The following is a description of a gene set: species: Mus musculus Mouse Gene Set: GOBP_DEFINITIVE_ERYTHROCYTE_DIFFERENTIATION Erythrocyte differentiation which occurs as part of the process of definitive hemopoiesis., and this is the list of marker genes: Smarca4, Rbfox2, Zfpm1, Gata1, Cdk5rap3, Senp1, Tgfbr3, Ncor1